The following is a description of a gene set: Mouse Gene Set: GOBP_PROTEIN_POLYMERIZATION The process of creating protein polymers, compounds composed of a large number of component monomers; polymeric proteins may be made up of different or identical monomers. Polymerization occurs by the addition of extra monomers to an existing poly- or oligomeric protein. species: Mus musculus, and this is the list of marker genes: Fkbp4, Arl2 (ADP-ribosylation factor-like 2), Evl, Alox15, Capza1b, Hspa1a, Golga2, Mtpn, Nck2, Myadm, Fga, Svil, Avil, Ankrd53, Esam, Slain2, Was, Zfp207, Daam2, Vtn, Nck1, Mzt1, Fchsd1, Tppp3, Arpc3, Twf1, Dyrk1a, Spta1 (NCBI Gene Id 98361), Nav3, Tmod2, Arhgap28, Ccdc66, Snx9 (sorting nexin 9), Cdk5rap2, Prex1, Haus2, Arhgef7, Rhod, Cttn, Kirrel1, Arhgap40, Sptan1, Bag4, Arpc5, Lats1, Fbxo5, Lmod2, Map4, Tubb4a, Cav3, Casq2, Cotl1, Cav1, Cfl1, Mtss1, Tppp, Cdc42ep3, Rdx, Hsp90aa1, Ccdc57, Gas7, Ssh3, Add2, Gsn, Capza2, Cdh5 (cadherin 5), Msrb1, Camsap2, Cdkn1b, Mapre3, Vdac2, Rps3, Ppp1r9a, Coro1a, Kif21a (NCBI Gene Id 16564), Psrc1, Togaram1, Tmod3, Ube2srt, Kank1, Fhod3, Pik3r2, Apc, Wasl, Gda, Nme7, Cyfip2, Diaph2, Prkcd, Eml2, Ambra1, Hdgfl3, Ckap5, Git1, Nckap1l, Add1, Fgf13, Casq1, Map1b, Sptb, Dbnl, Tmod4, Carmil1, Ccl11, Ttbk1, Dmtn, Tmsb15b2, Bin1 (NCBI Gene Id 30948), Kank3, Drg1, Crp, Cdc42ep5, Mlst8, Tbcd, Rac1, Arf6, Pcnt, Baiap2l2, Hcls1, Tubg1, Capzb, Scin, Tenm1, Lmod1, Mapt, Arpc2, Cdc42ep1, Capn1, Washc3, Fgb, Pfn1, Met, Ccl21f, Cenpj, Snca, Slit2, Capza3, Prkce, Kank4, Ccl21b, Fhdc1, Myh9, Cyrib, Csnk1d, Rictor, Pfn5, Krt5, Arpc4, Tlr2, Mapre1, Akap9, Lmod3, Camsap1 (NCBI Gene Id 96963), Ttc17, Flii, Ube2c, Ssh1, Clasp1, Rhoa, Septin2, Fchsd2, Abitram, Vill, Icam1 (intercellular adhesion molecule 1), Ptk2b, Cracd, Camsap3, Rasa1, Ube2s, Csf3, Washc5, Ssh2, Mecp2, Chmp3, Gpx4, Cdc42ep4, Tubb1 (tubulin, beta 1 class VI), Map2, Kank2, Stmn2, Slc39a12, Abl1, Ube2k, Prune1, Cdc42ep2, Fmn1 (NCBI Gene Id 99456, formin 1), Sgk1, Cd2ap, Chmp2a, Fer, Clec2i, Actr3, Tubg2, Slain1, Nphs1, Sptbn1, Hspa1b, Micall2, Tpm1, Baiap2, Hax1, Ndel1, Nefl, Mtor, Ssna1, Pde4dip, Nde1, Dbn1, Inpp5j, Baiap2l1, Add3, Coro7, Mkks, Arpc5l, Clip3 (CAP-GLY domain containing linker protein 3), Chmp4b, Diaph1, Diaph3 (NCBI Gene Id 80466), Tubgcp2, Wdr72, Pycard, Pak1, Trim6, Dlg1, Hip1r, Twf2, Clip1, Mapk8, Pfn2, Pak3, Pfn3, Cobl, Ang, Tuba1a, Map3k1, Tpx2, Ccl26, Cyfip1 (NCBI Gene Id 29878), Eln, Aif1, Trpv4, Cep192, Capza1, Gm14137, Arhgap18, Vil1 (villin 1), Ccl21a, Mid1ip1, Map7d3, Tmsb15l, Grb2, Tmsb4x, Bbs4, Fgg, Vasp, Washc1, Cyria, Nin, Carmil2, Numa1, Trim32, Rnf135 (ring finger protein 135), Stmn1, Ccl24, Plekhg2 (NCBI Gene Id 192230), Tppp2, Capg, Myo1c, Eps8, Msrb2, Pecam1, Arfgef1, Arl6 (ADP-ribosylation factor-like 6), Prkn, Dctn1, Dnm2, Tmod1, Nckap1, Clasp2, Tubgcp4, Ccl21e, Nedd1, Rp1, Tubgcp6, Gba2, Tubgcp5, Ccl21d (NCBI Gene Id 65956), Tubgcp3, Catip (ciliogenesis associated TTC17 interacting protein), Fam107a, Orc4, Fes